Given this list of marker genes HTR3A, HTR3B, HTR3C, HTR3E, HTR3D, here is a description of the gene set: Human Gene Set: GOCC_SEROTONIN_RECEPTOR_COMPLEX species: Homo sapiens A protein complex that is capable of serotonin receptor activity.